The following is a description of a gene set: Abnormal glomerular basement membrane morphology studied in species Homo sapiens Human Gene Set: HP_ABNORMAL_GLOMERULAR_BASEMENT_MEMBRANE_MORPHOLOGY Any abnormal sttructure of the glomerular basement membrane., and this is the list of marker genes: NOS1AP, DGKE, COL4A5, RNU7-1, COL4A4, GATA3, COL4A3, UMOD, CD151, LMX1B, CFH, ARHGDIA, CEP83